Given this list of marker genes NCKAP1L, SRMS, CUL3, TREM2, RRAGB, AKT1, OTUB1, F3, LIN28A, OGT, CTNS, LAMTOR2, LEP, LAMTOR1, TBK1 (TANK binding kinase 1), WAC (WW domain containing adaptor with coiled-coil), SLC38A9, RRAGA, PIK3CA, FLCN, CLEC16A, USP9X, SEH1L, PIM1, F7, GPR137B, PIP4P1, EP300, RPS6KB1, MIR199A1, GPR155, XBP1, CSNK1A1 (NCBI Gene Id 55416), USP4, GPR137C, SAMTOR, CCL5, MIOS, OTUD7B, SHQ1, STAMBPL1, CASTOR1 (cytosolic arginine sensor for mTORC1 subunit 1), HDAC3, FNIP1, LARS1, RICTOR, LAMTOR3, RHEB, MLST8, WDR59, MAT2A (methionine adenosyltransferase 2A), FNIP2 (NCBI Gene Id 57600), RBX1, WDR24, LAMTOR4, GPR137, GOLPH3, RRAGC, AKT3, OTUD5, GAS6, RRAGD, SEC13, SMCR8, KLHL22, RNF167, SYK, SIK3, RPTOR, RELN, PRMT1, PIH1D1, F10, LAMTOR5, SRC, HTR6, USP32, SESN2, here is a description of the gene set: Any process that activates or increases the frequency, rate or extent of TOR signaling. studied in species Homo sapiens Human Gene Set: GOBP_POSITIVE_REGULATION_OF_TOR_SIGNALING